The following is a description of a gene set: Human Gene Set: MIR8074 from publication Chen Y, Wang X (PMID 31504780) Genes predicted to be targets of miRBase v22 microRNA hsa-miR-8074 in miRDB v6.0 with MirTarget v4 prediction scores > 80 (high confidence targets). species: Homo sapiens, and this is the list of marker genes: UBQLN1, RUNX2, DCUN1D4, ADO, RMDN1, FOXO1, EVI5, SOCS6, ZBTB34, KDM7A, MAN1A1, NRP2, THBS3, RORA, NRBF2, SEPTIN7, CORO2B, ROCK2